Given this list of marker genes MAP3K20, FBXW4, TP63, SEM1, FGFR2, DLX6, PORCN, GLI3, DLX5, EPS15L1, BTRC (NCBI Gene Id 8945), WNT10B, UBA2, here is a description of the gene set: Human Gene Set: HP_SPLIT_FOOT species: Homo sapiens Split foot A condition in which middle parts of the foot (toes and metatarsals) are missing giving a cleft appearance. The severity is very variable ranging from slightly hypoplastic 3rd toe over absent 2nd or 3rd toes as far as oligo- or monodactyl feet.